Given this list of marker genes Slc6a2, Slc18a3, Slc18a1, Slc18b1, Slc6a4, Slc29a3, Slc22a2, Slc22a1, Slc18a2, Slc22a3, Slc6a3, Slc29a4, here is a description of the gene set: Enables the transfer of monoamines, organic compounds that contain one amino group that is connected to an aromatic ring by an ethylene group (-CH2-CH2-), from one side of a membrane to the other. species: Mus musculus Mouse Gene Set: GOMF_MONOAMINE_TRANSMEMBRANE_TRANSPORTER_ACTIVITY